The following is a description of a gene set: species: Mus musculus Mouse Gene Set: chr2E5, and this is the list of marker genes: Gm14020 (predicted gene 14020), Tmco5, Gchfr, Gm13983, Plcb2, Pla2g4b, Gm28042 (predicted gene, 28042), Lcmt2, Rpap1, Gm14021, Knstrn, Mapkbp1, Gm13998, Serinc4, Rad51, D330050G23Rik, 2810405F15Rik, H3f3c, Gatm (NCBI Gene Id 98899), Hypk, Rap1a-ps2, Gm13986, Tgm5, Map1a, Gpr176, Bloc1s6os, Tmem62, Exd1 (NCBI Gene Id 241624), Gm14213, Gm14138, Oip5os1, 2700033N17Rik, B2m (NCBI Gene Id 12010), Gm14207, Ppip5k1, Phgr1, Gm14058, Gm25308, Sptbn5, Slc28a2, Ttbk2, Snap23, Spint1, Serf2, Pla2g4f, Itpka, 4930417H01Rik, Pla2g4d, Terb2, Uqcrh-ps2, Gm14016, Mfap1a, Rpusd2, Gm25189, Spg11 (SPG11, spatacsin vesicle trafficking associated), Disp2, Adal, Rps12-ps10, Duox2, Eif3j1, Mir147, Lrrc57, Ctdspl2, Gm13990, Mir674, Ivd, Sqor, Gm24409, Tyro3, 1700054M17Rik, Mfap1b, Gm14137, Pla2g4e, Meis2, Jmjd7, Gm13982, Ino80, Gm23858, Bloc1s6, Srp14, Dll4, Thbs1, AA467197, Mageb3, Trim69, Epb42, Eif2ak4, Gm14017 (NCBI Gene Id 668887), Gm25857, Pdia3, Rhov, Sord, Slc28a2b, Zfyve19, Ckmt1, Ltk, Bambi-ps1, Ubr1, Nusap1, Capn3, Cdan1, Slc30a4, Ccdc32, Bahd1, Mir7665, Wdr76, Fam98b, Haus2 (HAUS augmin-like complex, subunit 2), Vps39, AV039307 (NCBI Gene Id 99260), Rtf1, Ell3, 4930412B13Rik, Chp1, Patl2, Bub1b, Gm14208, Zfp106 (NCBI Gene Id 22647), Trp53bp1, Ccndbp1, Ndufaf1, Inafm2, Gm13997, Gm14089, Dnajc17, Gm29340, Ganc, Fsip1, Zscan29, Mga, Vps18, Tmem87a, Gm14175, Pak6, Ankrd63, Shf, Spred1, Ccdc9b, Tubgcp4, Catsper2, n-R5s204, A930104D05Rik, Gm14050, Gm23814, Knl1, Gm13981, Golm2, Snord3b-ps2, Rmdn3, Rasgrp1, Chst14, Gm13991, Gm14018, Duox1, Gm13999, Duoxa1, Gm14383, Tgm7, Frmd5, Ppp1r14d, Bmf, G630016G05Rik, Duoxa2, Gm25514, Chac1, Ehd4, Stard9, Strc, Oip5